Given this list of marker genes Tefm, Nupr1, Arl2, Macroh2a1, Slc25a23, Uqcc2, Park7, Tnf, Slc25a33, Ak4, Mlxipl, Myog, Tmem135, Ppif, Dnajc15, Pde2a, Actn3, Apoc3, Myc, Vcp, Abcd1, Ide, Pink1, Nop53, Trpv4, Atp7a, Shmt2, Rhoa, Akt1, Iscu, Cbfa2t3, here is a description of the gene set: studied in species Mus musculus Any process that modulates the frequency, rate or extent of aerobic respiration. Mouse Gene Set: GOBP_REGULATION_OF_AEROBIC_RESPIRATION